Given this list of marker genes Mogat2, Dgat2, Awat2, Dgat1, Lpgat1, Mogat1, here is a description of the gene set: Catalysis of the reaction: acyl-CoA + 2-acylglycerol = CoA + diacylglycerol. studied in species Mus musculus Mouse Gene Set: GOMF_2_ACYLGLYCEROL_O_ACYLTRANSFERASE_ACTIVITY